The following is a description of a gene set: Genes predicted to be targets of miRBase v22 microRNA mmu_miR_7015_5p in miRDB v6.0 with MirTarget v4 prediction scores > 80 (high confidence targets). species: Mus musculus Mouse Gene Set: MIR_7015_5P from publication Chen Y, Wang X (PMID 31504780), and this is the list of marker genes: Prkaa1, Pdcd6, Hephl1, Slc35a3, Cep350, Csde1, Six4, Krt1, Raph1, Pck1, Stat2, Gnai1, Pknox1, Galr2, Nr2c2ap, Eml1, Pcdh10, Marchf2, Asb1, Snap23, Agap1, Vamp3, Bambi, Psg25, Mgrn1, Igf2r, Lpp, Gpr137b, Aplp2, Snx25, H2az2, Spty2d1, Xpnpep3, Xrcc2, Llgl2, Ang5, Cs, Crebrf, Zbtb18, Nrbp1, Sort1, Mylip, Sec22b, Phtf2, Abraxas2, Palld, Pdap1, B3galnt2, Atp10a, Rapgef2, Slc11a2, Prkx, Rimkla, Ttl, Ppara, Osgin2, Gpr173, Lemd3, Stk35, Ephb3, Prpf38b, Msi2, Mtch2, Cgn (cingulin), Bmal1, Sp4, Amdhd1, Kynu, Wdcp, BC005537, Cdc42bpa, Kat6a, Celf1, Slc9a1, Usf2, Trim59, Tnks, Slc35f1, Tnfaip3, Dsel, 1110004F10Rik, Lonrf1, Adrb1, Itsn1, Zmynd11, Myorg, Rhoq, Dock3, Adamts7, Acsl1, Tfam, Cpne8, Fchsd2, B3gat1, Gskip, Arfip1, Prrt3, Dnaaf9, Sar1a, Ing5, Tnrc6b, Dlg5, Etl4, Rap2c, Rapgef6 (Rap guanine nucleotide exchange factor (GEF) 6), Atp2c1, Gpc5, Mier3, Pcnx2, Arhgap1, Zfp518a, Kirrel1, Rbms1, Crtc3, Thumpd1, Wwp1, Fam162a (NCBI Gene Id 70186), Spc24, Col8a1, Cdin1, Adcyap1 (NCBI Gene Id 11516), Mybpc1, Rora, Anks1b, Tjp1, Abhd17c, Cluh, Ago4, Bicd1, Gapvd1, Sumo1, Dpysl5, Tmem236, Zfp704, Mat1a, Abca2, Arl8b, Glcci1, Rtn4rl1, Usp9x, Ang (NCBI Gene Id 11727), Litaf, Sebox, Foxb1, Cers6, Ang4, Lrp8, Slc24a3, Mark2, Fam114a1, Ino80, Mpp7, Nploc4, Insrr, Arfgef3, Serpina3n, Musk, Clk3, Sema4c, Psg29, Tm9sf3, B4galt2, Spred1, Aftph